The following is a description of a gene set: The chemical reactions and pathways involving UDP-N-acetylglucosamine, a substance composed of N-acetylglucosamine, a common structural unit of oligosaccharides, in glycosidic linkage with uridine diphosphate. studied in species Mus musculus Mouse Gene Set: GOBP_UDP_N_ACETYLGLUCOSAMINE_METABOLIC_PROCESS, and this is the list of marker genes: Gfpt1, Gnpda1, Pgm3, Uap1, Gnpnat1, Gfpt2, B4galnt2, Gne, Mgat1, Amdhd2, Gnpda2, Uap1l1, Dpagt1